The following is a description of a gene set: This event has been computationally inferred from an event that has been demonstrated in another species.<p>The inference is based on the homology mapping from PANTHER. Briefly, reactions for which all involved PhysicalEntities (in input, output and catalyst) have a mapped orthologue/paralogue (for complexes at least 75% of components must have a mapping) are inferred to the other species. electronically inferred by orthology from the curated human pathway Reactome Pathway: Prostanoid ligand receptors studied in species Mus musculus part of: Eicosanoid ligand-binding receptors, and this is the list of marker genes: Ptgdr, Ptger2, Tbxa2r, Ptgir, Ptger1, Ptgdr2, Ptger4